The following is a description of a gene set: studied in species Homo sapiens Genes up-regulated in comparison of primary splenic B cells from wild type mice versus those from Xid mice. Human Gene Set: GSE2826_WT_VS_XID_BCELL_UP Bruton's tyrosine kinase (Btk) is important for B lymphocyte development. To identify genes that are differentially expressed in primary B cells lacking functional Btk, splenocytes from X-linked immunodeficiency (Xid), Btk knockout (KO) and immunocompetent CBA mice, were used in microarrays containing more than genes and expressed sequence tags (ESTs). We found 4515 transcripts expressed in duplicate experiments in all three strains. Out of these, 38 were differentially expressed genes (21 up-regulated >2 fold and 17 down-regulated <-2 fold) between CBA and Btk defective mice. Ten out of these genes were selected and quantitative Real-Time PCR was conducted for validation and further investigation. Real-Time experiments correlated nicely with the microarray data. No definitive phenotypic difference has previously been reported between Xid and Btk KO mice. We found genes, whose expression differed (>2 fold) between the two strains. Moreover, when the genes, which differed between immunocompetent CBA and Btk defective mice were ranked according to fold-increase, the levels in Btk KO mice were significantly more altered. This suggests that the defect in Btk KO mice is more severe and demonstrates that the mutant Btk protein in Xid mice does not generally function as dominant negative form. from publication Lindvall JM, Blomberg KE, Berglöf A, Yang Q, Smith CI, Islam TC (PMID 15214046), and this is the list of marker genes: EPHX1, CD9, ISG15, UGDH, TMEFF2, RAD52, GCG, TARBP2, MARCKSL1, GHITM, ID3 (inhibitor of DNA binding 3), PIGA, CDC20, ATP5F1D, PRPF38B, LDHC, HADHB, COA6, GUCY2C, SPA17, FABP1, CD200, PIGS, LTK, CX3CL1, SFT2D1, CUL3, TBL1XR1, PTS, TLE4, DDX41, HELLS, ESRRA, RABGGTB, FAAH, GIMAP4, SLX9, KLHDC4, POLD4, STAG1, CD2AP (CD2 associated protein), NOTCH4, HSPA2, INVS, DGKA, NHSL3, SLC4A1AP, SIPA1, POLR3A, ETFA, SLC25A3, WDR6, GIMAP1, CSTF3, SPNS1, KDELR1, CCL22, MPP1, DERL1, PABPC4, MAST3, TRIM59, MYO1D, EPB41, MIF4GD, PSPN, CMTM6, MUTYH (NCBI Gene Id 4595), RAP1GAP, RECQL5, IGHG1, CCR1, RC3H2, BTD, IARS1, NCOA2, NID1, SIPA1L2, SLC9A8, APOF, MCM4, CMPK1, CASP7, MAN1A1, IL2RG, ADPRH, DNAJB5, TPI1, GPN3, EDEM1, IL4I1, CD38, HIVEP2 (NCBI Gene Id 3097), TEC, OTP, XRCC1, SMYD5, WASHC3, VWA7, S1PR3, ST3GAL6, PTPRA, GCSH, MS4A6A, PCP4, SRSF6, SMIM11, TNFAIP8, SLC6A2, HDAC1, RCBTB1, ACE (angiotensin I converting enzyme), CHEK2, LIN7C, CDIPT (CDP-diacylglycerol--inositol 3-phosphatidyltransferase), BCL2L13, CDK1, DHRS3, SLC19A1, BCL2A1, IGHM, MC2R, ROCK1, MIIP, AURKB, PCLAF, ANGEL2, RNASEH2A, C9orf78, RASAL1, SNRPD2 (small nuclear ribonucleoprotein D2 polypeptide), TWSG1, PPA1, MCM5, CRAT, NKAIN1 (NCBI Gene Id 79570), BCAT2, RECQL, AKAP8L, ROR2, CCL1, DYNC1H1, ETNK1, PDGFRB, LIPC, EIF3G, GTF2A1, AP1B1, PPP3CC, GTF2A2, GAD2, PRIM1, ARHGAP29, DFFB, TK1, FASTKD5, B3GNT2, ZNF740, NEK7, UBLCP1, GNG2, ASB6, TRIM27, HDAC3, TUBA3C, MVK, SH2D2A, SNX2, KLF7, NVL, ATG4B, FABP3, PTPRJ, MCOLN2, UBL5, LMO7, CD83, LSM2, SHISA5, BID, CASP1, ENDOU, ACKR2, GDI1, SLC25A19, SLC1A1, NDRG1, PLSCR1, NUDT16L1, IFI30, SLC50A1, GDAP1, SMYD2, GALK2, KCNK3, IL4R, PPIB, EBI3, EDN3, SRPRA